The following is a description of a gene set: Mouse Gene Set: GOCC_CMG_COMPLEX A protein complex that contains the GINS complex, Cdc45p, and the heterohexameric MCM complex, and that is involved in unwinding DNA during replication. species: Mus musculus, and this is the list of marker genes: Cdc45, Mcm6, Gins2, Mcm4, Gins4, Mcm5, Gins1, Gins3, Mcm7, Mcm3, Mcm2